Given this list of marker genes SLC26A6, SLC26A10P, SLC25A11, SLC26A8, SLC22A6, SLC1A5, SLC46A1, ABCC2, SLC25A12, SLC25A21, SLC1A1, SLC13A2, SLC26A5, SLC13A5, SLC26A2, SLC26A7 (solute carrier family 26 member 7), SLC19A1, SLC25A22, SLC25A10 (solute carrier family 25 member 10), SLC26A1, UCP2, SLC22A7, SLC25A18, SLC26A4, SLC16A1, SLC26A3, SLC1A6, SLC1A4, SLC26A9, SLC25A13, SLC13A3, here is a description of the gene set: Human Gene Set: GOMF_DICARBOXYLIC_ACID_TRANSMEMBRANE_TRANSPORTER_ACTIVITY Enables the transfer of dicarboxylic acids from one side of a membrane to the other. A dicarboxylic acid is an organic acid with two COOH groups. studied in species Homo sapiens